The following is a description of a gene set: Any process that modulates the potential difference across a presynaptic membrane. studied in species Mus musculus Mouse Gene Set: GOBP_REGULATION_OF_PRESYNAPTIC_MEMBRANE_POTENTIAL, and this is the list of marker genes: Kcnj11, Gabrr1, Kcna4, Gabra5, Kcnh1, Kcnj8, Kcna2 (NCBI Gene Id 16490), Gria3, Casr, Kcnj3, Scn1a, Gabrb1, Kcna1 (potassium voltage-gated channel, shaker-related subfamily, member 1), Rimbp2, Grik2, Gabbr1, Kcnc2, Kctd8, Gabra2, Kctd12, Kcnj9, Grin3b, Kcnj6, Grik3, Gria1, Glra1, Kctd16, Htr3a, Grin2d (glutamate receptor, ionotropic, NMDA2D (epsilon 4)), Grik4, Kcnmb4, Grik5, Kcnc1